The following is a description of a gene set: Phosphorylation is important in p53-mediated DNA damage responses. After UV irradiation, p53 is phosphorylated specifically at murine residue Ser389. Phosphorylation mutant p53.S389A cells and mice show reduced apoptosis and compromised tumor suppression after UV irradiation. We investigated the underlying cellular processes by time-series analysis of UV-induced gene expression responses in wild-type, p53.S389A, and p53(-/-) mouse embryonic fibroblasts. The absence of p53.S389 phosphorylation already causes small endogenous gene expression changes for 2,253, mostly p53-dependent, genes. These genes showed basal gene expression levels intermediate to the wild type and p53(-/-), possibly to readjust the p53 network. Overall, the p53.S389A mutation lifts p53-dependent gene repression to a level similar to that of p53(-/-) but has lesser effect on p53-dependently induced genes. In the wild type, the response of genes to UV irradiation was strictly biphasic. The early stress response, from 0 to 3 h, results in the activation of processes to prevent the accumulation of DNA damage in cells, whereas the late response, from 12 to 24 h, relates more to reentering the cell cycle. Although the p53.S389A UV gene response was only subtly changed, many cellular processes were significantly affected. The early response was affected the most, and many cellular processes were phase-specifically lost, gained, or altered, e.g., induction of apoptosis, cell division, and DNA repair, respectively. Altogether, p53.S389 phosphorylation seems essential for many p53 target genes and p53-dependent processes. species: Mus musculus from publication Bruins W, Bruning O, Jonker MJ, Zwart E, van der Hoeven TV, Pennings JL, Rauwerda H, de Vries A, Breit TM (PMID 18195040) Human Gene Set: BRUINS_UVC_RESPONSE_VIA_TP53_GROUP_A Category A genes: p53-dependent genes whose expression in the absence of S389 phosphorylation is similar to loss of TP53 in MEF (embryonic fibroblast) cells in response to UV-C irradiation., and this is the list of marker genes: SEZ6L2, ECT2L, NRBP2 (NCBI Gene Id 340371), CHODL, NLRP5, IFITM3, MB21D2, RNF151, SPMIP4, RASIP1, C2orf72, RHOH, RFLNB, CCL27, GSDMA, LEAP2, ATG16L2, EPX, VTN (vitronectin), CMTM5, NTRK2, CLDN4, LYSMD3, DHRS7C, FRAT1, SPMIP8, MTNAP1, AP5S1, PRSS2, OR13C7, CLPS, ANKRD2, CES2, LMAN2 (NCBI Gene Id 10960), SMIM18, WDR89, DST, ELF5, GNGT2, DPF3, TMED7 (NCBI Gene Id 51014), DNAJB4, LRRC58, GABRA2, PARP6, POU5F2, KIF16B, EMC6, WNK4, CXCR5, PLXNA2, ANKS6, PIP5K1B (phosphatidylinositol-4-phosphate 5-kinase type 1 beta), SLC25A53, KIT, PCSK1N, OR2A7, CYP2B6, MISP, GCC2, FBXO21, ATXN10, WNT5B, ACAN, SOBP, NT5ELP (5' nucleotidase, ecto-like, pseudogene), POU3F2, MED1, CD55, B3GNT2, RTN2, STK32B, WDR86, CNTNAP4, MCOLN2, MATN3, ARPP21, TMEM160, PDGFC, RPS6KA5, MYO1C, PDZK1IP1, FLVCR2, P2RX1, LCP2, THY1, PGM5, STK33, SPINT1, LPXN, C11orf86, INHBB, CABCOCO1, HPX, SLC17A6, RASGRP2, PTCD1, LYPD5, NAT8L, SPATA24, LHFPL4, PCNX4, MYL7, PLA2G4A, EVI5L, MAP3K20, NCLN, RAB11FIP1, CDH20 (cadherin 20), CCDC93, TTC1, THEM5, DBNDD1, NR3C1, CEACAM4, TTC9B, CEMIP, CA1, PRRX2, LIMK1, GPRC5C, ZNF2, UCP2, G0S2, TMEM150A, GAPDH (NCBI Gene Id 2597), IGSF5, CMYA5, ACTL6B (NCBI Gene Id 51412), ADAM22 (ADAM metallopeptidase domain 22), VRK3, TTN, XPOT, CRYAA, RSL24D1, CLDN3, CD164, CYP51A1, SLC39A4, ANPEP, MYL3, CLDN34, CD247, SMAD6, GIPC2, PGBD5, MYL12A (myosin light chain 12A), WDR1, DMRTB1, ZFR2, SMARCD3, MAPK10, SLPI, SEC16B, ECEL1, UNCX (UNC homeobox), BCL2L13, SHISAL1, ASB2, DCHS1, ADGRL4 (adhesion G protein-coupled receptor L4), SLIRP, SEMA5A, MYO5C, HOXC4, PCNT, LRRC4, LYVE1, VSTM2B, TCAP, SUPT4H1, LYSMD2, MXD3, ITGA7, DKK3, LPAR3 (NCBI Gene Id 23566), DNAJB12, APBA2, FKBPL, TSPAN33, ICAM2, CIDEB, ATP8A1, UCK2, FEM1B, GNPNAT1, NTN3, SOX11, GLA, SPAG1, MAP3K4, TEX14, CEL, CSTPP1 (NCBI Gene Id 79096), PRLR, IL17RA, DTD2, PDE7A, ACE2, HAS1, IL4, CACNG4, CCDC28B, CYP4B1, MYO1B, ACP5, KIF3B, SIGMAR1, KCNAB3, GNAZ, MOK, IPPK, TRAPPC12, KIRREL3, SULT1E1 (sulfotransferase family 1E member 1), MLKL (NCBI Gene Id 197259), EGR2, CADM3 (NCBI Gene Id 57863), PAOX, GREM1, PECAM1, KRT12, ZCCHC4, SLCO1C1, GTF2F1, PLEC, DDX25, C1orf122 (chromosome 1 open reading frame 122), ADGRE4P, NFIL3, C4orf19, GSTM2, PATJ, DOCK6 (NCBI Gene Id 57572), ADD2, CFC1B, LMOD1, GPATCH2, TBK1, GNPAT, ARHGEF3, TBC1D5, BEND5, FKBP1A, ZNF467, NOG, GALNT4, PAG1, CCDC198, KLC4, REXO5, PCOLCE, CGA, SDC2 (NCBI Gene Id 6383), PDS5A, ATP2A1, PNPO, SENP7, NUP62, CDH1, TMEM106B, YWHAG, ABCC1, CIB4, CPB2, CMBL, MUC16, NKD1, PER1, NDP, PTPN5, CACNA1D, UCMA, LMAN1, JAK3, TFR2, SLC4A4, TOX4, ASPRV1, SLC25A24, RUNDC3A, ATG101, HOXA-AS3, TAX1BP3, MOBP, GP9 (glycoprotein IX platelet), FBLN7, LCA5, PRKCQ, GPR65, SNCA (synuclein alpha), RNF208, ZNF419, RNF125, TRMO, PCDHB13, GLP2R, SIGIRR, CRYGA, DNMBP, GIMAP4, BCL6 (NCBI Gene Id 604), TWF1, DOCK4, CREB3L4, ARC, CCDC88C, RNH1, STEAP2, GIMAP1, MOSPD3, AIRN, IRAK1, PNOC, RPTN, MEG3, ARRB1, LXN, ARHGEF26, UBE2L6, MZB1, CLGN, ATG2B (NCBI Gene Id 55102), CALML4, RGS7BP, CLIC4, CELSR1, LRRC46 (leucine rich repeat containing 46), RASSF8, CAPN5, CD47, OR12D2, ZNF708, MC4R, EHMT1, BCAR3, GLOD4, FCER2, ZZEF1, SLC35F4, PTPRD, ART4, DBX1, FN3K, DOCK7, FEZF1, LENEP, SLC30A7, BCAS3, FANCD2OS, ACER2, RAB38, CACNA2D2, RASGRP1, KLF9, BDH1, ITGA9, OR51E2, LAT2, FYCO1, GATA1, SMIM3, METRN, BCL2, PRSS36, ANKRD24, BNIP2, UBE3B, HSD17B7 (NCBI Gene Id 63064), RASA2, TTC9, RAC3, MGST3, CRYBA2, KBTBD11, PRR29, SSTR2, CYP1B1, CSRP1, FOXC1, PEDS1, CTF1, CA5A, NADK2, RAB3A, STEAP1, DKK1, EPS8L3, PACRG, SRPRB, MYT1L, TAF1B, TNC, TMEM88, KCTD9, DOCK5, KIF5B, MYOZ1, TFDP2, CRLF2, STK38, PRDM2, TOB1, ZIC4, NUDT16L1 (NCBI Gene Id 84309), GNG3, BICC1, SELENBP1, WIF1, MED15, KLKB1, ANKRD33B, IMPA1, SEMA5B, AHSG, GPR155, DMXL2, DAB2, OCSTAMP, TM4SF4, DYSF, BRSK2, BRCA2, CNN1, RFLNA, SERINC3, GGPS1, MAP4 (NCBI Gene Id 4134), CBFA2T3, DNAAF4, BHMT2, ELAVL3, EGFL6, HGD, GLDC, APCS, EMID1, ZNF235, DCSTAMP, MBD4, TULP3, COL11A2, DPH1, DSPP, AKAP5, MRPL10, CTHRC1, DDR1, KRT34, RBM47, MPV17L, FAM240B, TSR3, CAPG, GPR160, ABHD18, CAMK2D, SLC16A2, CD69, MYO3A (myosin IIIA), U2SURP, ADAMTS9, MIR205HG, KDM4B, IL1RL2, MAGI1, GM2A, BCL11B, UTP23, FAHD2A (fumarylacetoacetate hydrolase domain containing 2A), VPS33A, PIK3R1, APBA3, DCAKD, TENM4, XRN1, NUDT12, LDB2, PPFIA3, ENTPD1, NAAA, RGS8, COL27A1, SEZ6, RND3, SNORC, ITFG1, DHCR7, NRGN, HOXD3, ENPP1, MMP13, NNAT, RNF6, POU2F1, TRPV4, RPS6KA4, PSORS1C2, VSX1, ISLR, PRDM16, MPLKIP, SLC25A30 (NCBI Gene Id 253512), ITGB6, RAB3C, VAMP2, PDCD4, MAG, COL13A1, CEBPB, ITGA5, SLC22A16, COL22A1, GPC5, FAM219A, TM4SF20, APOA4, PDXDC1, DHRS3, SULT1C3, PTGIR, ATP2B1, SVIP (small VCP interacting protein), SLC35D3, RBM18, ANO9, IER3, WNT10A, UNKL, CD248, PPP2R2A, CNTFR, PNKD, DCAF11, HELZ, GNG10, VCAM1, YKT6, PI4K2B, ADAMTS8, NCAN, HSPB2, SERPINB12, DYNLT1, CD93, C14orf119, SH3KBP1, LECT2, RIPOR1, TRIB3, CACNA1S, MAPK6 (mitogen-activated protein kinase 6), AGBL3, RHBDF1, SNX7, FGF19, NPL, C2, PDIA2, KYNU, TMEM161B, C5orf47, MYBPH, NHSL1 (NCBI Gene Id 57224), MCF2L, MYO5A, CTSE, LNX1, FETUB, OSBPL10, SLC7A9, LURAP1L, CYP2D6, AGTRAP, SPACA1, ISYNA1, PYGO2, SLX1A (NCBI Gene Id 548593), ARPC4, CPXM2, SERPINA3, ASIC2, SLC6A20, RAB33A, CNOT10, CLTC, TEK, IREB2, DPEP3, LYPD8, FOXB2, KRT85, PRKCI, FXYD7 (FXYD domain containing ion transport regulator 7), IFT88, KLF12, TAAR1, FXYD2, C14orf93, TTYH3, CMA1, STRN3, NOC3L, SOCS5, ISL2, APOA5, ALPL, ZNF536, FNBP1, SLC44A4 (solute carrier family 44 member 4), SNAP91, FOSL1, RRH, PCTP, NME3, MPHOSPH10, ACTN3, TEX101, GPRASP1, KRIT1, TECTA, TUSC3, PBX2, PRB1, CACNG2 (calcium voltage-gated channel auxiliary subunit gamma 2), CALY, ERO1B, SMAGP, CHGA, APH1B, GATM, HMBOX1, DHODH, ZCCHC12, CX3CL1, AMDHD1, CHM, MYO5B, SOCS4, SLC25A23, CAMSAP3, NTM, SLC46A3, EEF1A2, NEAT1, FOXA2, CDHR5, KRT16, SLITRK1, CSTA, C1orf21, TEAD1, ARSB, B3GALT5, IRX4, ZNF436, ENTPD8, ZNF121, VXN, CUEDC1, PWP1, ENTPD2, SAPCD1, CACNA1G, SNORD7, PPP1R1C, STAC, HIVEP3, SLC30A6, NHSL2, ATF3, FADS3, SYNE2, DAD1, TRAPPC3, C6orf120, SERPINH1, TUBB4A, HSD11B2, ELANE, MAP7D2, CECR2, KNDC1, ALDOB, CYP3A5, CORO6, CALML5, SRY, NOL9 (nucleolar protein 9), TNNT1, ELAPOR1, CAT, CTSG, EDNRA, BPIFA3, FAM162B, PIGW, LIPG, BMP5, ANKRD22, CCDC134, ASPA, DEFB1, LRRN3, LAS1L (NCBI Gene Id 81887), SEC62, WNT3, NCALD, SH2D4B, GSTT1, RNF111, NPAS3, NKX1-2 (NK1 homeobox 2), DMTN, FRMD5, ZNF358, ERP44, C3orf70, RMDN3, APOM, CLIP3, DSCAM, NAT1, VPS37A, HSD17B3, RNF180, MATCAP1, CEP295NL, PRELID2, MSTO1, NPAS1, FMO5, MAPRE1, KCNJ2, PATE4, PGRMC1, MS4A3, LCE3C, LEPROT, ARMC2, CNTN1, AKT3, MAP3K1, KIAA1210, SERPING1, TLR1, MAP3K8, AOX1, FNDC5, ALOXE3, SST, RYR1, GABRG1, BICD1, FXYD1, MYMK, ASCL1, CSRNP3, CAV3, CYP2J2, PLCL2, TSPAN9, CFB, ANGPTL6, ART3, KCNE1, TRAF5, WNT6, TMEM86B, DMGDH, GZMA, PAX3, RNF187, STAG3, KREMEN2, GALNTL6, SPMIP6, LIN7C, ILDR2, PPP2R2B, HSF4, KCTD10, ST3GAL2, TAPBP, ERO1A (endoplasmic reticulum oxidoreductase 1 alpha), UBN1, GATA3, ASL, KCNN1, AGRN, CKMT2, ADORA2B, ANXA13, NFATC2IP, SALL3, KCTD4, CHD6, CYP4F8 (cytochrome P450 family 4 subfamily F member 8), SLC6A4, OC90, NPR2, S100A14, GRHL1, AGER, SH2D4A, LAMP5, SPATS2L, MKRN2OS, WFIKKN2, C19orf44, FLNC, SPRYD7 (SPRY domain containing 7), CLCNKA, ITGA2B, LRP2, RIPOR2, GUCD1, ACOT9, FOS, MEF2C, ACVR2B, TSPO, TENM2, EPDR1, MAOA, PHYKPL, CEACAM21, LYPD2, GLIPR2, NEDD1, VSIR, RHAG, CYP11A1, FBXL22, SPAM1, LYPD3, HSPBAP1, KCNJ11, TMEM163, GNAO1, GOSR1, IFI44L, DEGS1, LYZL4, PRSS1, RUFY3 (NCBI Gene Id 441022), PTCH1, APPL1, NECAB2, SCUBE1, TMEM63A, SRPX (NCBI Gene Id 8406), CCDC125, NCMAP, RESP18, GPIHBP1, ACTA2, SFTPC, KLRC2, RNF220, ZNF780A, AFF3, ZBTB20, MPV17, MYO1H, COX7A2L, LY6G6E, RAB31 (RAB31, member RAS oncogene family), ABCG2, SMIM5, SIAE, TNFSF9, PTP4A1, HESX1, EVPL, ZDHHC13, SMIM1, SDF4 (stromal cell derived factor 4), COBL, HIPK2, GPR108, MYOZ2, ABTB3, XCL1, DGKE, ZGRF1, RABIF, GJC2, SLC6A14, ZEB2, ADAM15, OR56A5, SCPEP1, TLR4, REM1, MYO1E, FGD4, WNT5A, CLDN11